The following is a description of a gene set: from publication Chen Y, Wang X (PMID 31504780) Human Gene Set: MIR575 Genes predicted to be targets of miRBase v22 microRNA hsa-miR-575 in miRDB v6.0 with MirTarget v4 prediction scores > 80 (high confidence targets). species: Homo sapiens, and this is the list of marker genes: ANK3, CSNK1G3, AKAP13, ELAVL4, ELOVL6, STOX1, PCDH19, SNRPD3, CEP128, FBXW11, NDEL1, ANKRD61, CHSY3, WEE1, PURA, DENND5A, CADM2, ZNF425, ZNF142, YPEL5, WNK3, ST7L, EPB41L5, DIPK2A, OSMR, MBD4, POLR3B, USP49, ZNF516, LSM12, ABCD3, TSSK1B, WDFY3, DYNC1LI2, PLPPR4, CXXC5, CHD9, MEF2C, GUCY2C, ZNF398, RIPK4, ANKRD23, SBNO1, RBBP5, ZNF827, DCUN1D4, ITGA2, BTBD3, DPP8 (NCBI Gene Id 54878), CEP85L, DOCK5, TPT1, EPOR